Given this list of marker genes IGKC, FASLG, NFKB2, PSMB10, CCND1, STAT2, RNF31, PIK3R1, NHLRC2, UNG, MOGS, CNBP, CR2, REL, CD81, PSMB8, IL2RB, CTLA4, AICDA, SYK (NCBI Gene Id 6850), SPI1, STIM1, CD40, CARD10, PIK3CG, CTPS1, CASP10, SH2D1A, TNFRSF9, RFXAP, SLC19A1, PGM3, XIAP, ALG12, SP110, IKBKG, SEC61A1, PDCD1, MAP3K14, ARHGEF1, RASGRP1 (RAS guanyl releasing protein 1), ORAI1, FAS, TRMU, LRBA, TONSL, TNFRSF11A, SON, DOCK11 (NCBI Gene Id 139818), KMT2D, EXTL3, TLR8, IVNS1ABP, NCKAP1L, NFKBIA, EPG5, ITK, KDM6A, TCF3, RFX5, RNF168, POLD3, FNIP1, MGAT2, IL21, NAE1, PMM2, BLM (BLM RecQ like helicase), NLRP1, RAG1, CD19, PTPRC, ZBTB24, CD3E, RFXANK, VPS33A, RAC2, RNF113A, CD3G, ERCC2, CD3D, PIK3CD, MS4A1, ATP6AP1, IL6ST, CASP8, B2M, LCK, SLC5A6, IRF2BP2, IL7R, BTK, RAG2, TNFRSF13B, ATM, IGHG2, IL2RG, TOM1, CD79B, CXCR4, LYN, LIG1, TYMS, JAK3, PSMB9, STING1, DCLRE1C (DNA cross-link repair 1C), PRIM1, SPPL2A, POMP, KNSTRN, DOCK8, TNFRSF13C, POLD1, SH3KBP1, TGFB1, CBLB, SPINK5, BACH2 (BTB domain and CNC homolog 2), CD40LG, CD247, IPO8, BLNK, TPP2, ADA, IFIH1, IL6R, SASH3, TCN2, IRF8, CSNK2A1, IFNGR1 (interferon gamma receptor 1), ICOS, here is a description of the gene set: Abnormal circulating IgG concentration studied in species Homo sapiens Human Gene Set: HP_ABNORMAL_CIRCULATING_IGG_CONCENTRATION An abnormal deviation from normal levels of IgG immunoglobulin in blood.